The following is a description of a gene set: Any process that activates or increases the frequency, rate or extent of retinoic acid receptor signaling pathway activity. Mouse Gene Set: GOBP_POSITIVE_REGULATION_OF_RETINOIC_ACID_RECEPTOR_SIGNALING_PATHWAY species: Mus musculus, and this is the list of marker genes: Aldh1a3, Ctbp2, Klf2, Asxl1, Nr2c1 (nuclear receptor subfamily 2, group C, member 1)